The following is a description of a gene set: species: Mus musculus Plasma lipoprotein clearance Mouse Gene Set: REACTOME_PLASMA_LIPOPROTEIN_CLEARANCE, and this is the list of marker genes: Apob, Apoc4, Ap2b1, Npc2, Uba52, Ubc, Uba52rt, Soat2, Pcsk9, Ces3b, Ap2a2, Clta, Soat1, Ap2m1, Ap2s1, Ldlr, Nceh1, Cltc, Scarb1, Apobr, Npc1, Apoa1, Lipc, Apoc1, Lipa, Ap2a1, Rps27a, Nr1h2, Hdlbp, Vldlr, Mylip, Ubb, Nr1h3, Ldlrap1, Apoe, Ces3a